Given this list of marker genes CSAD (NCBI Gene Id 51380), MPST, SQOR, GOT1, SUOX, AHCY, ETHE1, MTR, GCLC, CDO1, CBS, BHMT, GSS, CTH, MAT1A, here is a description of the gene set: Cysteine and methionine catabolism Human Gene Set: WP_CYSTEINE_AND_METHIONINE_CATABOLISM species: Homo sapiens